Given this list of marker genes FBXL12, MAGT1, GNL3L, SPRED2, AGBL5, SLC22A5, C3orf62, ATMIN, PLEKHA3, STAP1, SGSM3, NOP16, FAM209A, TMEM239, EIF4E (NCBI Gene Id 1977), FITM2, MFSD5, RNF19A, IL2RA, TP53INP2, WDR12, TRIT1, PLEKHB2, NKAPD1, UBOX5, RBM12, MGA, SUV39H1, RAB10, CD164, GPR18, TGM2, BTNL2, NDUFAF4, IPO4, PPP1R2P1, ATP6AP2, NRG4, MIER2, CHRNA9, WWC1, TWIST2, MOSMO, TECPR1, HNRNPM, WEE1, PRR3 (NCBI Gene Id 80742), VPS11, TFIP11, CENPJ, RIMOC1, ANKRD49, PGRMC2, STAT4, YARS2, SLC35B3, IDH3A, MYO1D, WDR37, RPS6KA5, MATR3, CPLANE1 (ciliogenesis and planar polarity effector complex subunit 1), RNF11, ZDHHC14, DCT, NFATC3, TMEM68, HDC, PPP2CB, TEX15, CD34, TESK1, KCNC2, GORAB, ARGLU1, AKR1C3, MEF2A, NUP107, CGAS, PTPN22, IPO7, FAM149A, CCNA2, PHF20, EPS15L1, DDX19B, TCP1, CDC42BPG, MAP9, ALKBH5, REV1, ADAM10, NXT2, ACOX1, ACKR4 (NCBI Gene Id 51554), CRNKL1, EPHX3, SLC25A44, LGR6, NXNL2, VPS33B, RELB, STAT3, DCK, SIGMAR1, MAP3K1, CHD7, RCC2 (regulator of chromosome condensation 2), SRP54, GADD45A, FAM174A, FGF13, ACVR2A, CCDC169, FAM43A, EEPD1, NRBF2, TEX55, CALR, TDRD7, RPS27, FOXC1, TTLL11, TUFT1, CCND2, TES, SETDB1, IARS1, PHF23, EHD1, SIGLEC1, NFYC, RNF125, YIPF5, GPR153 (NCBI Gene Id 387509), PDCD6, BMAL1, MTFR1, ZDHHC15, KIF15, DDX55, VCPKMT, LMNA, PNO1, PPP2R1B, TRIM27 (tripartite motif containing 27), ISG20L2 (NCBI Gene Id 81875), FAM204A, SNHG17, BYSL, SYCN, TCF7L2, SRCAP, RNF157, SNX2, HECA, HSF4, QSOX2, ZBTB21, UTP3 (NCBI Gene Id 57050), EED, INTS15, PDCD6IP, TVP23B (trans-golgi network vesicle protein 23 homolog B), SUPT5H, PCLAF, GNPNAT1, GDAP2, TACC3, PRRT1, TRAK1, RRP9, RCN2, CCDC59, CMTM6, R3HCC1L, TRIM23, LIN28B, ZNF7 (zinc finger protein 7), MED17, SLC1A5, IL15RA, ARV1, NUP133, USP25, TSR2, RAD21, RRP1, ZFP82 (ZFP82 zinc finger protein, NCBI Gene Id 284406), EIF3G, RRAS2, TREML2, PMPCB, RELL1, TMEM125, RUNDC1, NUP62, JAK1, DLGAP1, SON, here is a description of the gene set: studied in species Homo sapiens Human Gene Set: GSE20198_IL12_IL18_VS_IFNA_TREATED_ACT_CD4_TCELL_DN Genes down-regulated in the activated CD4 T cells (48h): IL-12 and IL18 versus interferon alpha. from publication Filén S, Ylikoski E, Tripathi S, West A, Björkman M, Nyström J, Ahlfors H, Coffey E, Rao KV, Rasool O, Lahesmaa R (PMID 20304822) The aim of this study was to identify genes regulated by IL-12, IL-18 and IFN-alpha during early differentiation of human Th1 cells